Given this list of marker genes Frk, Baz1b, Tyk2, Fgr, Abl2 (NCBI Gene Id 98214), Ptk6, Lyn, Dyrk1a, Fes, Fer, Tnk2, Tnk1, Pkdcc, Syk, Srms (src-related kinase lacking C-terminal regulatory tyrosine and N-terminal myristylation sites), Zap70, Lck, Blk, Melk, Jak1, Styk1, Yes1, Wee1, Itk, Bmx, Btk, Csk (c-src tyrosine kinase), Eif2ak2, Jak2 (NCBI Gene Id 98155), Abl1, Jak3, Ripk2, Txk, Ptk2, Matk, Wee2, Peak1, Ptk2b, Prkcd (NCBI Gene Id 52581), Tec, Stk16, Fyn, Src, Hck, here is a description of the gene set: Mouse Gene Set: GOMF_NON_MEMBRANE_SPANNING_PROTEIN_TYROSINE_KINASE_ACTIVITY studied in species Mus musculus Catalysis of the reaction: ATP + protein L-tyrosine = ADP + protein L-tyrosine phosphate by a non-membrane spanning protein.